Given this list of marker genes FOXO3, CD55, TOX, ADPRM, IRF2, AGL, DOCK5, ZEB2, CYLD, ST8SIA4, NEDD4, GAS7, IKZF3, STX4, CX3CR1, DYNLT3, GSK3B, DST, EOMES, SPAST, APOE, CCPG1, CCL5, KLF3, TBC1D5, DAPK2, MDC1, PACSIN1, RBL2, ACAD10, EP300, NCK1, ZBTB7A, FAM120B, ZDHHC20, CD7, SEPTIN4, ADGRG1, PPM1B, FRY, CASP4, CST7, KCNJ8, CASP1, ST6GALNAC3 (NCBI Gene Id 256435), CD63 (CD63 molecule), LGALSL, RNF215, OC90, ISG20, GUCY1A1, TRPS1, PRR5L, ATF7IP, GEM, AKIRIN2, RSAD2, ULK2, PLOD2, THEMIS2, TNFSF4, CCND2, SEC23A, CELA1, PRKDC, GIMAP1, RIGI, CCNC, SYT11, LONP2, VAV3, RPL37A, GLCCI1, PENK, TNFSF10, EIF4B, DUSP1, KIF5C, PCMTD1, S1PR5 (sphingosine-1-phosphate receptor 5), NKG7, SUOX, SLC4A1AP, DMXL1, ASXL2, PRAP1, APBB1IP, CD226, OCIAD2, FYN, GCA, MX2, PHACTR2, NEDD9, DDX60, NIBAN1, TUT7, DZIP3, CD200R1L, CD3E, DDX17, C1QC, IKZF2, BAZ2B, SP100, VAMP5, JUNB, KLF2, PHYH, PTPN13, LCLAT1, SERTAD1, CHD9, ZFYVE27, JCHAIN, N4BP2L1, CCNG1, NIPAL3, STAT2, SLC50A1, ZMAT1, SECISBP2L, ABTB2, KIAA1958, IZUMO4, LRRC8C, YPEL3, SH2D1A, ARID4A, MBLAC2, LATS2, CD38, UNC45B, TOX2, ARMCX3, SERPINI1 (serpin family I member 1), NSMAF, CXCR6, CHD3, TEC (tec protein tyrosine kinase), TRIM5, RGS2, CEP350, SMIM14, CD3G, ORMDL3, IFT25, IFIH1, AIRN, ITPR2, SLPI, RPL17, ING1, S100G, METTL4 (NCBI Gene Id 64863), PLEKHA1, ZBTB2 (zinc finger and BTB domain containing 2), BBX, LAX1, TSGA10, PPP1R12A, AS3MT, ZUP1, SRGAP3, ESYT2, GNPTG, here is a description of the gene set: studied in species Homo sapiens from publication Arenzana TL, Smith-Raska MR, Reizis B (PMID 19329779) The development, homeostasis and function of B lymphocytes involve multiple rounds of B cell receptor (BCR)-controlled proliferation and prolonged maintenance. We analyzed the role of transcription factor Zfx, a recently identified regulator of stem cell maintenance, in B cell development and homeostasis. Conditional Zfx deletion in the bone marrow blocked B cell development at the pre-BCR selection checkpoint. Zfx deficiency in peripheral B cells caused impaired generation of the B-1 cell lineage, accelerated B cell turnover, depletion of mature recirculating cells, and delayed T-dependent antibody responses. Zfx-deficient B cells showed normal proximal BCR signaling, but impaired BCR-induced proliferation and survival. This was accompanied by aberrantly enhanced and prolonged integrated stress response, and delayed induction of Cyclin D2 and Bcl-xL proteins. Thus, Zfx restrains the stress response and couples antigen receptor signaling to B cell expansion and maintenance during development and peripheral homeostasis. Human Gene Set: GSE13547_2H_VS_12_H_ANTI_IGM_STIM_ZFX_KO_BCELL_UP Genes up-regulated in B lymphocytes stimulated by anti-IgM: ZFX knockout (2h) versus wildtype (12h).